Given this list of marker genes Dcp2, Lsm2, Patl1, Dcp1a, Edc4, Edc3, Ddx6, Lsm1, Lsm7, Lsm6, Lsm4 (LSM4 homolog, U6 small nuclear RNA and mRNA degradation associated), Lsm3, Dcp1b, Lsm5 (NCBI Gene Id 72095), here is a description of the gene set: species: Mus musculus Mouse Gene Set: REACTOME_MRNA_DECAY_BY_5_TO_3_EXORIBONUCLEASE mRNA decay by 5' to 3' exoribonuclease